Given this list of marker genes POLR1D, MKKS, POLR1B, DOCK2, TCTN3, RNU12, RECQL4, TCOF1, SALL1, DACT1, UBR1, SPINT2, FREM1, IL10RB (NCBI Gene Id 3588), CCNQ, PI4KA, PIGN, MID1, CDK8, LONP1, POLR1C, SALL4, DDB1, KIF7, MNX1, JAK3, here is a description of the gene set: Human Gene Set: HP_RECTAL_FISTULA Rectal fistula The presence of a fistula affecting the rectum. studied in species Homo sapiens